Given this list of marker genes BNIP3, MIR133A1, BMP7, MYOCD, NACA, MIR145, SMAD4, CAPN2, HEY2, CAMK2A, MIR16-1, RPS6KA2, MDK, SIRT5, MIR17, GATA4, PPP1R10, HSPB6, PAX8, NFE2L2, BAG3, SIRT4, NKX2-5, MAP3K5, CAMK2D, MIR195, JAK2, MIR21, MIR320A, NRG1, SFRP2, KIFAP3, ATP2A2 (ATPase sarcoplasmic/endoplasmic reticulum Ca2+ transporting 2), TP53, MIR30E, NOL3, AMBRA1, MIR19A, MIR24-1, HSF1 (NCBI Gene Id 642255), LTK, ATG5, MIR20A, MIR19B1, APAF1, MIR34A, PDPK1, ENG, MIR106B, TIGAR, NOTCH1, ADCY10, BMPR1A (NCBI Gene Id 8035), CFLAR, PTPN1, GNGT1, HAND2, RGL2, MIR199A1, NUPR1, HSP90AA1, here is a description of the gene set: Human Gene Set: GOBP_STRIATED_MUSCLE_CELL_APOPTOTIC_PROCESS studied in species Homo sapiens A form of programmed cell death induced by external or internal signals that trigger the activity of proteolytic caspases, whose actions dismantle a striated muscle cell and result in its death. Striated muscle cells make up striated muscle fibers which are divided by transverse bands into striations.